The following is a description of a gene set: studied in species Mus musculus Mouse Gene Set: GOBP_PHOSPHATIDYLSERINE_ACYL_CHAIN_REMODELING Remodeling the acyl chains of phosphatidylserine, through sequential deacylation and re-acylation reactions, to generate phosphatidylserine containing different types of fatty acid acyl chains., and this is the list of marker genes: Mboat2, Lpcat3, Pla2g2f, Mboat1, Lpcat4